Given this list of marker genes SPRR1A, SERPINB2, IL1R2, SULT2B1, SNRPA1 (NCBI Gene Id 88988), SMCP, HMGCS1, PRIM1, CTSV, UBE3B, CD24, PSG1, NMT2 (NCBI Gene Id 9397), THRB, HBB, SAMD9, DSC2, MXD1, SPRR2E, LCN2, SLPI, IFIT1 (NCBI Gene Id 8374), DSP, IFI44, KLK7, LRP1, GPA33, DEGS1, IFI35, MX2, TAGLN, PLA2G1B, GBP1, STAT1, PTPRU, FOS, ENTPD3 (NCBI Gene Id 956), ACVR2B, BPGM, MVD (NCBI Gene Id 4597), IFITM1, CDKN1A, PRSS1, KLK6 (kallikrein related peptidase 6), LAMA3, TRIB1, PEA15, DSG1, AR, OAS2, IFI27 (interferon alpha inducible protein 27), MX1, TEX29, DMKN, IL1RN, PTGS2, PHF7, LYST, CBFA2T2, TRIM22, here is a description of the gene set: Human Gene Set: CHANG_IMMORTALIZED_BY_HPV31_DN studied in species Homo sapiens Human papillomaviruses (HPVs) infect keratinocytes and induce proliferative lesions. In infected cells, viral gene products alter the activities of cellular proteins, such as Rb and p53, resulting in altered cell cycle response. It is likely that HPV gene products also alter expression of cellular genes. In this study we used microarray analysis to examine the global changes in gene expression induced by high-risk HPV type 31 (HPV31). Among 7,075 known genes and ESTs (expressed sequence tags) tested, we found that 178 were upregulated and 150 were downregulated twofold or more in HPV31 cells compared to normal human keratinocytes. While no specific pattern could be deduced from the list of genes that were upregulated, downregulated genes could be classified to three groups: genes that are involved in the regulation of cell growth, genes that are specifically expressed in keratinocytes, and genes whose expression is increased in response to interferon stimulation. The basal level of expression of several interferon-responsive genes was found to be downregulated in HPV31 cells by both microarray analysis and Northern blot analysis in different HPV31 cell lines. When cells were treated with alpha or gamma interferon, expression of interferon-inducible genes was impaired. At high doses of interferon, the effects were less pronounced. Among the genes repressed by HPV31 was the signal transducer and activator of transcription (Stat-1), which plays a major role in mediating the interferon response. Suppression of Stat-1 expression may contribute to a suppressed response to interferon as well as immune evasion. from publication Chang YE, Laimins LA (PMID 10756030) Genes down-regulated in normal keratinocytes immortalized by infection with the high risk HPV31 (human papilloma virus) strain.